The following is a description of a gene set: Human Gene Set: HP_ABNORMAL_ULNAR_METAPHYSIS_MORPHOLOGY Abnormal ulnar metaphysis morphology Any structural abnormality of the portion of the ulna between the epiphysis and the diaphysis. studied in species Homo sapiens, and this is the list of marker genes: RECQL4, COL10A1, ANAPC1, COL2A1, SNRPN, NDN, COMP, MAGEL2, MMP9, MMP13